Given this list of marker genes Bmp2, Stard10, Lmo3, Jund, Ptgis (NCBI Gene Id 19223), Alox8, Fabp5, Gps2, Lep, Cited2, Asxl2, here is a description of the gene set: species: Mus musculus Any process that activates or increases the frequency, rate or extent of the peroxisome proliferator activated receptor signaling pathway. Mouse Gene Set: GOBP_POSITIVE_REGULATION_OF_PEROXISOME_PROLIFERATOR_ACTIVATED_RECEPTOR_SIGNALING_PATHWAY